Given this list of marker genes PIGT, GPC4, MYT1L, CACNA1A, SOX4, EXOC2, NXN, B3GLCT, SUPT16H, ZMIZ1, ZNF462, HNRNPU, CLCN3, MED27, MEG3, NRCAM, RTL1, ATP1A3, SLC1A3, H3-3A, ROR2, SNIP1, DLK1, MED25, SMARCA2, KIF7, POGZ, KMT2A, HNRNPK, TBCK, SLC35A2, DNMT3A, ATP1A2, CHD8 (chromodomain helicase DNA binding protein 8), CAMSAP1, TRIP12, TMEM94, JARID2, RALA, here is a description of the gene set: Human Gene Set: HP_EXAGGERATED_CUPID_S_BOW studied in species Homo sapiens More pronounced paramedian peaks and median notch of the Cupid's bow. Exaggerated cupid's bow